Given this list of marker genes Tyk2, Abcc1, Bag6, Il12a, Elf4, Il23a, Cd300a, Rasal3, Il15, Il12b, Zbtb7b, Clec4f, Il18, Myc, Jak2, Hsph1, Cd1d1, Cd1d2, here is a description of the gene set: Mouse Gene Set: GOBP_NK_T_CELL_ACTIVATION studied in species Mus musculus The change in morphology and behavior of a mature or immature natural killer T cell resulting from exposure to a mitogen, cytokine, chemokine, cellular ligand, or an antigen for which it is specific.